Given this list of marker genes Ccnb1, Ins2, Ttk, Pdgfrb, Anapc7, Il1a, Mad2l1bp, Drd3, Obsl1, Fgfr3, Cd28, Pdgfb (platelet derived growth factor, B polypeptide), Dync1li1, Tpr, Gen1, Psmg2, Btc, Nme6, Fgfr2, Kntc1, Knl1, Tom1l2, Cul7, Apc, Cdc16, Igf1, Ska3, Epgn, Edn1, Ndc80, Tnf, Sphk1, Anapc15-ps, Cdca8, Rad21 (RAD21 cohesin complex component), Anapc11, Pebp1, Trip13, Birc5 (NCBI Gene Id 11799), Spc24, Prap1, Bora, Bub3, Tgfa, Mad2l1, Lrp5, Ccnb1-ps (cyclin B1, pseudogene), Zfp207, Smpd3, Pdxp, Rcc1, Zw10, Arhgap33os, Hoxa13 (homeobox A13), Fbxw5, Cdc42, L3mbtl1, Anapc5, Tex14, Bub1 (NCBI Gene Id 99145), Nusap1 (nucleolar and spindle associated protein 1), Tubg1, Chek1, Xrcc3, Zwint, Bmp4, Cdk5rap2, Ywhah, Pcid2, Anapc15, Fbxo5, Plk1, Ereg, Igf1r, Spc25, Haspin, Dusp1, Bmp7, Usp44, Aurkb (NCBI Gene Id 20877), Egf, Il1b, Cdca2, Igf2, Ube2c, Cdc23, Dmrt1, Zwilch (NCBI Gene Id 68014), Spdl1, Sh2b1, Cdc20, Ins1, Edn3, Fbxo43, Tom1l1, Mtbp, Ccdc8, Rb1, Ik, Met (met proto-oncogene), Esr1, Mad1l1, Klhl22, Insr, Rgcc, Cep192, Mki67, Incenp, Nfe2l1, Nsmce2, Fgf8, Prpf4b, Cdk11b, Cenpe, Atm, Phip (pleckstrin homology domain interacting protein), Lcmt1, Nuf2, Cav2, Ska1, Khdc3, Nup62, Bub1b, Cul3, Cul9, here is a description of the gene set: species: Mus musculus Mouse Gene Set: GOBP_REGULATION_OF_MITOTIC_NUCLEAR_DIVISION Any process that modulates the frequency, rate or extent of mitosis.